The following is a description of a gene set: Human Gene Set: HP_DECREASED_TOTAL_T_CELL_COUNT studied in species Homo sapiens The absolute number of T cells per volume is below the lower limit of normal. Decreased total T cell count, and this is the list of marker genes: NBN, PRKDC, RFX5, BTK, EXTL3, FCHO1, PGM3, BCL11B, PTPRC, SP110, FOXN1, RAG2, TBX2, ADA, RIPK1, MCM10 (minichromosome maintenance 10 replication initiation factor), IL7R, CD3G, LAT, RNF31, ACP5, TOM1, RAC2, IL2RG, EPG5, ATM, PSMB10, RAG1, MAP3K14, UNC119, SYK, IL2RA, IRF1, DOCK8, JAK3, MYD88, STAT1, NHEJ1, PIK3CD, DNMT3B, DOCK2, RFXANK, IL7, POLD3, CD3D, RFXAP, CD247, CIITA (NCBI Gene Id 4261)